The following is a description of a gene set: Human Gene Set: GOBP_NEGATIVE_REGULATION_OF_AMIDE_METABOLIC_PROCESS species: Homo sapiens Any process that stops, prevents, or reduces the frequency, rate or extent of the chemical reactions and pathways involving amides., and this is the list of marker genes: MIR29C, SPHK1, PRKAA1, GGA3, ABCA7, MIR29A, IGF1, RTN4 (NCBI Gene Id 57142), MIR339, SPON1, MIR153-1, HAP1, PIN1 (peptidylprolyl cis/trans isomerase, NIMA-interacting 1), RTN1, MIR29B1, RTN3, MIR15B, MIR361, ORMDL2, APOE, PRNP, ORMDL1, PGK1, MIR298, MIR103A1, MIR455, RTN2, MIR15A, MIR24-1, ORMDL3, NTRK2, BIN1, ROCK1, CLU, MIR16-1, MIR186, SORL1, CHRNA7